The following is a description of a gene set: Any process that results in a change in state or activity of a cell or an organism (in terms of movement, secretion, enzyme production, gene expression, etc.) as a result of an ionomycin stimulus. Human Gene Set: GOBP_RESPONSE_TO_IONOMYCIN species: Homo sapiens, and this is the list of marker genes: ZC3H12A, PLCB1, ZNF683, CDK4, CAV3, CD4